The following is a description of a gene set: Human Gene Set: GOBP_RIBONUCLEOSIDE_MONOPHOSPHATE_METABOLIC_PROCESS studied in species Homo sapiens The chemical reactions and pathways involving a ribonucleoside monophosphate, a compound consisting of a nucleobase linked to a ribose sugar esterified with phosphate on the sugar., and this is the list of marker genes: DPYD, AK2, UPP1, MPP1, PNP (purine nucleoside phosphorylase), AMPD3, CAD, PRPS1L1, ADSL, RFK, HPRT1 (NCBI Gene Id 3251), ADK, IMPDH2, ADSS2, NT5C1A, GMPR2 (NCBI Gene Id 51292), UPB1, UPP2, CDA, UCK1, AK1, DCK, GDA, UMPS, NT5E, NT5C, UPRT, ATIC, AK3, UCKL1, NUDT2, PRPS1, ADA, AMPD2, CMPK1, DLG2, DLG1, PFAS, PRPS2, ADSS1, UCK2 (uridine-cytidine kinase 2), PAICS, PRTFDC1, GUK1, NT5C2, DPYS, CASK, LRGUK (leucine rich repeats and guanylate kinase domain containing), DHODH, IMPDH1, MAGI3, AMPD1, XDH, CARD11, TJP2, PPAT, GART, AK4, GMPS, APRT